The following is a description of a gene set: An ion channel complex through which sodium ions pass. Human Gene Set: GOCC_SODIUM_CHANNEL_COMPLEX studied in species Homo sapiens, and this is the list of marker genes: GRIK5, SCN11A, SCN1B, SCNN1B, SCNN1A, GRIK1, SCN1A, SCN3B, SCN2A, TRPM4, SCN8A, GRIK2, SCNN1D, SCN10A, GRIK4, SCN2B, SCN5A, SCNN1G, SCN4B, SCN9A, SCN4A, GRIK3, SCN7A, SCN3A